The following is a description of a gene set: species: Homo sapiens Human Gene Set: DESCARTES_FETAL_LUNG_MESOTHELIAL_CELLS Marker genes curated from the annotated cluster as represented in the Descartes Human Gene Expression During Development database. The gene expression program underlying the specification of human cell types is of fundamental interest. The study authors generated human cell atlases of gene expression and chromatin accessibility in fetal tissues. For gene expression, the study authors applied three-level combinatorial indexing to >110 samples representing 15 organs, ultimately profiling ~4 million single cells. The study authors leveraged the literature and other atlases to identify and annotate hundreds of cell types and subtypes, both within and across tissues. Our analyses focused on organ-specific specializations of broadly distributed cell types (such as blood, endothelial, and epithelial), sites of fetal erythropoiesis (which notably included the adrenal gland), and integration with mouse developmental atlases (such as conserved specification of blood cells). These data represent a rich resource for the exploration of in vivo human gene expression in diverse tissues and cell types. from publication Cao J, O'Day DR, Pliner HA, Kingsley PD, Deng M, Daza RM, Zager MA, Aldinger KA, Blecher-Gonen R, Zhang F, Spielmann M, Palis J, Doherty D, Steemers FJ, Glass IA, Trapnell C, Shendure J (PMID 33184181), and this is the list of marker genes: SPRR2F, PODN, UNC5B-AS1, FAM110C, CCN4 (cellular communication network factor 4), CFB, C1R, PTGIS, ADAMTS5, WT1, RNU6-977P, RSPO1, RERG, BDKRB1, DOK7, EIF4BP6 (NCBI Gene Id 645579), GLP2R, SMTNL2, CDH20, DKK1, PCOLCE2, PLA2G2A, PRODH2, NPHS1, LINC02643, CRIM1, IL6, CA9, LINC01996, PDZRN4, ELN, BDNF, PRSS33, MGP, RNU4-45P, CTSE, WNT2B, GFPT2, KLK5, ADCYAP1, PCK1, LINC02381, TECRL, OLR1, HAS1, CASC20, GATA4, TBX18, CLDN15, LINC02360, C3, GEM, GADL1 (glutamate decarboxylase like 1), LRRN4, LINC01687, PRG4, MSLN, FGF9, ASS1, KRT5, SOX15, LINC01018, MPPED2-AS1, SFRP5, PLAC9 (NCBI Gene Id 219348), MST1, RND1, SBSPON, NHERF4, CYP4Z1, ALDH1A2, GRIN2A, PRELP, CARNS1 (NCBI Gene Id 57571), LIF, GSG1L, KLHL31, CPA4, ITLN1, PSAPL1, ADGRD1, DSEL-AS1, PLLP, PTPRQ, TGM1, SULF1, FNDC1, EPCIP, MIR548XHG, COL8A2 (NCBI Gene Id 1296), TNNT1, BNC1, WT1-AS, CFH, TMEM52B, CRB2, NMU, GSDME, ABHD12B, NKX3-1, LINC01133, KLK1, CES5AP1, FGGY-DT, BST1